The following is a description of a gene set: species: Homo sapiens Human Gene Set: GOBP_RESPONSE_TO_PHEROMONE Any process that results in a change in state or activity of a cell or an organism (in terms of movement, secretion, enzyme production, gene expression, etc.) as a result of a pheromone stimulus., and this is the list of marker genes: TMEM145, VN1R4, GPR180, VN1R1, VN1R5, VN1R17P (NCBI Gene Id 441931), VN1R3, VN1R2, GNG8